The following is a description of a gene set: Reactome Pathway: Assembly of collagen fibrils and other multimeric structures This event has been computationally inferred from an event that has been demonstrated in another species.<p>The inference is based on the homology mapping from PANTHER. Briefly, reactions for which all involved PhysicalEntities (in input, output and catalyst) have a mapped orthologue/paralogue (for complexes at least 75% of components must have a mapping) are inferred to the other species. electronically inferred by orthology from the curated human pathway species: Mus musculus part of: Collagen formation, and this is the list of marker genes: Col7a1, Ctss, Loxl3, Mmp13, Col8a2, Loxl4, Col4a5, Col6a5, Col6a1, Mmp7, Col4a6, Loxl2, Mmp20, Col5a3, Col8a1, Col24a1, Col2a1, Col10a1, Loxl1, Col15a1, Lox, Col4a2, Bmp1, Pcolce, Col6a6, Mmp3, Col11a2, Col9a1, Col18a1, Tll2